Given this list of marker genes Ubc, Uba52, Ptpn11, Rps27a, Hck, Jak2, Ube2d1, Ubb, Lyn, Eloc, Csf3, Ube2d3, Elob, Syk, Kras, Shc1, Uba52rt, Ube2d2a, Grb2, Socs1, Socs3, Rnf7, Tyk2, here is a description of the gene set: Mouse Gene Set: REACTOME_SIGNALING_BY_CSF3_G_CSF Signaling by CSF3 (G-CSF) species: Mus musculus